The following is a description of a gene set: Human Gene Set: GOCC_FHF_COMPLEX A protein complex that is composed of AKTIP/FTS, FAM160A2/p107FHIP, and one or more members of the Hook family of proteins, HOOK1, HOOK2, and HOOK3. The complex is thought to promote vesicle trafficking and/or fusion, and associates with the homotypic vesicular sorting complex (the HOPS complex). species: Homo sapiens, and this is the list of marker genes: HOOK3 (hook microtubule tethering protein 3), AKTIP (AKT interacting protein), FHIP1B, HOOK1, HOOK2